The following is a description of a gene set: SUMO1, 2, and 3 are initially expressed as propeptides containing extra residues at the C-terminus. (SUMO1 has 4 residues, SUMO2 has 2 residues, and SUMO3 has 11 residues,) SENP1, 2, and 5 are endoproteases that process the precursors to produce the mature peptides. SENP1 processes SUMO1 with greater efficiency than SUMO2 or SUMO3. SENP2 and SENP5 process SUMO2 with greater efficiency than SUMO1 or SUMO3. SENP1 shuttles between the cytosol and nuceoplasm and is predominantly nuclear. SENP2 also shuttles and is mainly located on nucleoplasmic filaments of the nuclear pore complex. SENP5 is located mostly in the nucleolus (Di Bacco et al. 2006, Gong and Yeh 2006). Reactome Pathway: SUMO is proteolytically processed studied in species Homo sapiens part of: Processing and activation of SUMO, and this is the list of marker genes: SENP2, SENP5, SUMO3, SUMO1, SENP1, SUMO2